Given this list of marker genes Tmsb10, Pgm3, Mat2b (NCBI Gene Id 68881), Ifi27l2a, Sct, Rnf213, here is a description of the gene set: species: Mus musculus Mouse Gene Set: CUI_PDC_IL34_RESPONSE_UP Genes positively differentially expressed in cell type: pDC (plasmacytoid dendritic cell) upon treatment with cytokine: IL-34 in mouse lymph nodes in vivo. from publication Cui A, Huang T, Li S, Ma A, Pérez JL, Sander C, Keskin DB, Wu CJ, Fraenkel E, Hacohen N (PMID 38057668) Cytokines mediate cell-cell communication in the immune system and represent important therapeutic targets. A myriad of studies have highlighted their central role in immune function, yet we lack a global view of the cellular responses of each immune cell type to each cytokine. To address this gap, the authors created the Immune Dictionary, a compendium of single-cell transcriptomic profiles of more than 17 immune cell types in response to each of 86 cytokines (>1,400 cytokine-cell type combinations) in mouse lymph nodes in vivo. A cytokine-centric view of the dictionary revealed that most cytokines induce highly cell-type-specific responses. For example, the inflammatory cytokine interleukin-1β induces distinct gene programmes in almost every cell type. A cell-type-centric view of the dictionary identified more than 66 cytokine-driven cellular polarization states across immune cell types, including previously uncharacterized states such as an interleukin-18-induced polyfunctional natural killer cell state.